The following is a description of a gene set: species: Homo sapiens Human Gene Set: HP_KETOSIS Ketosis Presence of elevated levels of ketone bodies in the body., and this is the list of marker genes: POLG2, GK, GHSR, INSR, ZFP57, PYGL, TRMT10A, LYRM4, DLD, BTD (NCBI Gene Id 92108), PAX4, LRPPRC, GCK, GCDH, SLC5A2, ACSF3 (acyl-CoA synthetase family member 3), PHKG2, MMAA, KARS1, OXCT1, SLC25A4, EIF2AK3, IVD, NEUROD1, ITPR3, CIDEC, APPL1 (NCBI Gene Id 26060), PDX1, ACADM, MMUT, PHKA2, CLCNKB, MMAB, CA5A, KCNJ11 (potassium inwardly rectifying channel subfamily J member 11), KLF11, ABCC8, BLK, RRM2B, SUGCT, SLC37A4, INS, HNF4A, POLG, GYS2, PLAGL1, FBP1, SLC16A1 (solute carrier family 16 member 1), DBT, ACAT1, BCKDHA, HYMAI, HNF1A, SHOX, PPP1R15B, CYC1, IL6, COX6B1, MLYCD, CEL, SLC22A5, ATP5F1D, MCCC2, MRPL3, POLR3K, ABHD5, TWNK, PTPN22, SLC12A3